The following is a description of a gene set: from publication Cui A, Huang T, Li S, Ma A, Pérez JL, Sander C, Keskin DB, Wu CJ, Fraenkel E, Hacohen N (PMID 38057668) Mouse Gene Set: CUI_B_CELL_IL21_RESPONSE_UP Genes positively differentially expressed in cell type: B cell upon treatment with cytokine: IL-21 in mouse lymph nodes in vivo. studied in species Mus musculus Cytokines mediate cell-cell communication in the immune system and represent important therapeutic targets. A myriad of studies have highlighted their central role in immune function, yet we lack a global view of the cellular responses of each immune cell type to each cytokine. To address this gap, the authors created the Immune Dictionary, a compendium of single-cell transcriptomic profiles of more than 17 immune cell types in response to each of 86 cytokines (>1,400 cytokine-cell type combinations) in mouse lymph nodes in vivo. A cytokine-centric view of the dictionary revealed that most cytokines induce highly cell-type-specific responses. For example, the inflammatory cytokine interleukin-1β induces distinct gene programmes in almost every cell type. A cell-type-centric view of the dictionary identified more than 66 cytokine-driven cellular polarization states across immune cell types, including previously uncharacterized states such as an interleukin-18-induced polyfunctional natural killer cell state., and this is the list of marker genes: Eif3c, Tubb4b, Ddx21, Anp32b, Txndc17 (thioredoxin domain containing 17), Hsp90ab1, Ncl, Sel1l, Eif4a1, Sgta, Atf6, Snrpa, Gspt1, Mrps7, Pgp, Uchl3, Ruvbl2, Ebna1bp2, Srsf9, Psme1, Mettl1, Ddx39a, Tmem238, Psma4, Pole4, Fbl, Eif3l (eukaryotic translation initiation factor 3, subunit L), Ppp1r14b, Stip1, Pebp1, Txn2, Wdr46, Nr2c2ap, Nudc, Nop10, Mif, Pdia6, Kcnq1ot1, Npm1, Lrrc59, Eif2s1, Pdia4, Tomm20, Odc1, Snrpd1, Skic8, Ddx18, Xbp1, Mybbp1a, Rbx1, Lsm2, Tomm40, Gnl3, Fxyd5, Canx, Utp18, Rraga, Ndufs6, Rpp14, Sbno2, Cct8, Sertad2, Phgdh, Eif2s2, Set, Ssb, Selenow, Hmgn3, Dnaja1, Nol8, Psma5, Ctsz, Pih1d1, St13, Slc25a5, Ran, Tars1, Rbm3, C1qbp, Atp5f1e, Mrpl3, Hspa8, Znrd2, Pa2g4, Lap3, Sf3b3, Ranbp1 (RAN binding protein 1), Serbp1, Chchd1, Atp5f1b, Phf11b, Eif1, Eif5a, Arpc2, Ormdl2, Mif4gd, Calr, Dynll1, Bank1, Uqcrq, Cox7b, Cct5, Bop1, Hnrnpd, Ndufv2, Hsp90b1, Mrpl46, Chmp2a, Drap1, Hcls1, Mrps24, Plekhf2, Srm, Ppia, Nhp2, Pdia3, Gmppb, Snrpd3, Manf, Cct2, Nop58, Atp5pb, Gpr171, Nsun2, Fkbp2, Myl12a, Ltv1, Timm8a1, Prdx1, Eef1e1, Myl6, Surf2, Slc7a1, Hspd1, Pum3, Cd38 (CD38 antigen), Sdf2l1, Mrpl28, Hspa5, Impdh2, Hikeshi, Sde2, Eprs1, Mars1, Psmb10, Gtpbp4, Snrpa1, Srsf2, Ptpn1, Srsf7, Ipo5, Ptges3, Ddx50, Cct3, Sar1b, Grb2, Actg1, Derl2, Snrpe, Tuba1b, Nme1, Cox5a, Ms4a1, Ndufa1, Etf1, Taf10, Ptma, Hspa9, Socs3, Lsm6, Abcf1, Exosc1, Psmb6, Alkbh1, Dnajb11, Rrp1, Cfl1, Ppp3ca, Rcl1, Atp5mc1 (NCBI Gene Id 11951), Tbl3, Rbmxl1, Pfn1